Given this list of marker genes SELENOP, GPC4, IQGAP2 (IQ motif containing GTPase activating protein 2), MAPRE3, LIMCH1, TANK, GNG2, RAB8B, APPL1, AAK1, RNF5, PCDHB16, SMARCA2, UTRN, BIK, ELK3, CD44, MID1, SSH1, CORO2A, CCND2, FOSL2 (NCBI Gene Id 79579), UBR1, TGFB2, NR2F1, ZNF277 (zinc finger protein 277), GPR160, PSMB9, PIK3CA (NCBI Gene Id 5290), TRIM23, PTP4A3, EPS8, AHR, HOXA3, PCMTD2, PDCD4, ELMO3, TBX3, MMP11, CDC42EP3, RASGRP1, RUNX2, MECP2 (methyl-CpG binding protein 2), GUSBP3, HERC4, U2AF1, PTMS, GPR88, TRIM2, CSRP2, PKN2, GFPT1, PTPRG, LITAF, PRKAB2, ZNF780A, DZIP3, LONP2, ARHGDIA, VWA5A, CAT, PPP3CB, FMO5, MYO10, TSC22D3, TRIP11, MYLIP, SLC2A10, ABAT, CREBL2, CARD8, SEPTIN3, ACOX1, KLF6, NUPR1, KDM5B, GGCX, RAD50 (RAD50 double strand break repair protein), FOXP1, FOXN3, NR5A2, ERAP2, SEPTIN6, NR1D1, CLSTN3, CCNG2, CYP2R1, KLF7, PIM1, MAST4, CMTM6, HBP1, FYN, CYP4V2, MXD4, NDUFB8, SNX25, SCNN1A, LGR5, NNT, ATF2, TRAK2, GLRX, ECH1, ZFYVE16, IFITM1, MBP, BICD1, BTG1 (BTG anti-proliferation factor 1), GADD45A, ALDH3A2, SIN3B (NCBI Gene Id 23309), SNTB1, BCL6, GSN, CROT, CD82, NRP1, BACE1, FDXR, here is a description of the gene set: Human Gene Set: RODRIGUES_DCC_TARGETS_DN Genes down-regulated in HCT8/S1 cells (colon cancer) which normally lack DCC compared to those stably expressing wild type DCC off a plasmid vector. from publication Rodrigues S, De Wever O, Bruyneel E, Rooney RJ, Gespach C (PMID 17334389) species: Homo sapiens Deleted in colon cancer (DCC) and UNC5 function as netrin dependence receptors by inducing apoptosis in the absence of their ligand and accordingly were recently designated as putative conditional tumor suppressors. Herein, we determined whether netrin-1 and its receptors are implicated in cancer cell invasion and tumor progression. Expression of DCC, UNC5 and adenosine A2B-receptors (A2B-Rs) was investigated by reverse transcription polymerase chain reaction in human colon cancer cells. The impact of DCC restitution and netrin-1 was evaluated on collagen type I invasion, tumor growth and metastasis in nude mice, cancer cell survival and gene expression profiling. Flow cytometry, poly(ADP-ribose)polymerase-1 and caspase-8 activation were used to evaluate the impact of DCC on cell death. Both netrin-1 and A2B-R activation induced the invasive phenotype through the Rho-Rho kinase axis in DCC-deficient human colorectal cancer cells. Restitution of wild-type DCC blocked invasion induced by netrin-1, A2B-R agonist and other agents. Ectopic expression of netrin-1 led to increased growth of human colon tumor xenografts in athymic mice. Conversely, introduction of wt-DCC in kidney MDCKts.src-ggl cells strongly inhibited metastasis in lymph nodes and lungs and increased sensitivity to apoptosis in hypoxia. DNA microarrays revealed that netrin and DCC had common and divergent impacts on gene expression linked to cell cycle, survival, surface signaling and adhesion. Our findings underscore that netrin is a potent invasion and tumor growth-promoting agent and that DCC is a metastasis suppressor gene targeting both proinvasive and survival pathways in a cumulative manner.